The following is a description of a gene set: Mouse Gene Set: GOCC_ENDOSOME studied in species Mus musculus A vacuole to which materials ingested by endocytosis are delivered., and this is the list of marker genes: Ap3m2 (adaptor-related protein complex 3, mu 2 subunit), Ptp4a3, Epha4, Cd2ap, Arrdc5, Il12b, Kcnq1, Itm2b, Mmd (NCBI Gene Id 69866), Rab7, Havcr2, Pla2g3, Commd1, Inhca, Gatd1, Rhoa, Tbc1d5, Mgrn1, Rhov, Atp6v0d2, D130043K22Rik, Atp6v1e1, Magi2, Rab27a, Parm1, H2-DMb1, Ackr2 (atypical chemokine receptor 2), Snx32, Snx11, Tpp1, Yipf1, Rab22a, Igf2r, Myo5b (NCBI Gene Id 383414), Ap1g2, Tpcn1, Rab23 (NCBI Gene Id 98704), Ehd1, Dbnl, Psap, Siglec1, Rab4a, Rffl, Rap2a, Tmem106b, Sla2, Rab5a, Ociad2, Tnk2, Tpcn2, Nipa1, Ap5b1, Washc1, Pigr, Snx21, Tmem30a, Leprotl1, Litaf, Slc2a2, Pacsin3, Cltc, Nsg1, Rabep2, Snx16, Dennd6b, Ptp4a1, Plekhj1, Kif16b, Derl1, Ifnar1, Cd164 (NCBI Gene Id 53599), Tnik, Ykt6, Chmp7, Pla2g4e, Smpd1, Scoc, Ntrk1, Pip5k1c, Ccr3, Snx18, Fzd7, H2-M10.4, Atp6v0d1, Sun2, Rftn1, H2-DMb2, Furin, Abhd6, Kcnk1, Slc9a3, Lztr1, Cmtm6, Ifitm2, Abcc5, Tubgcp4, Slc9a8, Dnm2, Cdip1, Cc2d1b, Dnm1l, Cst7, Rabep1, Rabgap1l, Arhgap44, Ap1s1, Slc9a5, Psen1, Mr1, Rab35, Rab11fip5, Atp6ap2, Lhcgr, Scamp4, Rnf167, Anxa8, Snx14, H2-Eb1, Vps39, Ap1b1, Grip1, Steap4, Plekhb2, L1cam, Entrep1, Ehbp1l1, Apoe, Slc2a4, Ap3b2, Vps13b, Rnf148, Sh3gl2, Pacsin2, Vps26a, Tnfaip1, Vps51, Arl8b, Sftpa1, Gosr2, Tmem150b, Arc, H2-M11, Tpt1, Ap1m1, Sdf4, Tbc1d14, Exoc8, Uevld, Mreg, Chmp3, Washc5, Tmem184a, Smo (smoothened, frizzled class receptor), Ngf, Ackr3, Fyn, Gnas, Rab11fip2, F2r, Ephb1, Trappc14, Coro1a, Rap2b, Trim27, C9orf72, Rab13, Inpp5b, Zdhhc11, Syt5, Syt11, Gja1, Hap1, Fzd5, Chmp5, Lamtor2, Hyal3, Cyba, Rab7b, Rab5c, Rapgef1, Slc11a2, H2-M10.6, Ap3s2, Traf3, Nedd4l, Nipa2, Acap1, Ctsd, Ldlrad4, Yipf2, Epha8, Bsg, Ehd3, Dtnbp1, Ptpn1, Tmem108, Tom1l1, Pank1, Plin3, Ncf4, Rasgef1b, Neurl1b, Akt2, Ret, Prkar1b, Slc36a2, Marchf3, Diaph3, Pheta1, Ccdc154, Rufy1, Ehbp1, Kir3dl1, Chmp4b, Phb1, Coro1c, Mrc1, Ubr4, Laptm4b (NCBI Gene Id 68111), Ap3m1, Pdcd6, Laptm4a, Inpp4a (inositol polyphosphate-4-phosphatase, type I), H2-M10.1, Gpnmb, Zdhhc1, Lamtor5, Oprm1, Ocrl, Fcgr2b, Snx25, Map1lc3a, Atg9a, Vamp3, Mon1b, Tmem163, Cxcr4, Arhgap1, Vps53, D6Wsu163e, Stx12, Tsg101, Tjap1, Psen2, Abca7, Atp7b, Slc48a1, Osbpl11, Vps4a, Myh9, Napepld (NCBI Gene Id 242864), Rab14, Tyrp1, Rps6kc1, Osbpl9, Ctse, Dio3, Ifitm3, Oca2, Fchsd1 (NCBI Gene Id 319262), Kcmf1, Slc30a3, Tm9sf4 (transmembrane 9 superfamily member 4), Wdr81, Tlr9, Rilp, Gzmb (NCBI Gene Id 14939), Slc5a1, Rac1, Rab20, Tgoln1, Hgs, Chid1, Ap1s3, Washc2, Cryzl1, Tmem175, Pi4k2a, Itgb1, Mvb12b, Uvrag (UV radiation resistance associated gene), Dll3 (delta like canonical Notch ligand 3), Snx20, Zfyve21, Plekhf1, Lgmn (NCBI Gene Id 19141), Abca5, Lipc, Myo1d, Cblif (NCBI Gene Id 14603), Atp13a5, Lamp1, Rnf133, Tmbim1, Pikfyve, Gapdh, Erbb2, Ehd2, Astn1, Bdkrb2, H2-T22, Ctss, Rab4b, Bloc1s1 (NCBI Gene Id 14533), Epha3 (Eph receptor A3), Pick1, Atp1a1 (NCBI Gene Id 229653), Slc26a7, Bltp3b, Numb, Steap3, Cts8, Eipr1, Amotl2, Cln6 (NCBI Gene Id 76524), Lmtk2, Trappc6b, Ubap1l, Agtr1a, Arrdc3, Sec31a, Trim3, Flot1, Chmp2b, Rab9, Grb2, Vamp5, Stambpl1, Arf1, Vps41, Nucb1, Slc46a2, Pip4p1, Trappc4, Dysf, Ccdc120, Mitd1, Apoa5, Epn2, Ankrd13d, Rnf149, Tbck, Ptpn23, Nox1, Fcgrt, Tlr8, Myo1b, Hsd17b6, Cytip, Ackr4, Rab31 (RAB31, member RAS oncogene family), Washc4, Amn, Ide, Negr1, Kif21b, Gpc1, Sppl2b, Grin2b, H2-Q1, Ccdc22, H2-Q6, H2-M5, Pi4k2b, Atp9b, Exoc4, Rab9b, Ap1s2, Sorl1, Tbc1d17, Vps33b, Rap2c, Ctns, Mfsd12, Sorcs2, Slc31a1, Zfyve28, Micall2, Tgfb2, Atp6v0a4, Snx8, Mapk3, Ap5s1, Rab8b, Tmub1, Rnf128, Vps25, Hps5, Abhd17b, Il12a, Zdhhc2, Vcam1, Crhbp, Rab37, Fgd5, Mib2, Mapkap1 (mitogen-activated protein kinase associated protein 1), Tmem25, Rab24, Ube2d3, Ankrd13a, Atp11a, Hps6, Prkcz, Rab3c, Wdr48, F8a, Rab27b, Atp10b, Avpr1a, Eea1, H2-Q10, Bst2, Vps29, Osbpl1a, Acap2 (ArfGAP with coiled-coil, ankyrin repeat and PH domains 2), Hspa8, Cdk2, H2-Q7, Vps35l, Trappc9, Chmp6, Vps50, Mvb12a, Ifitm7, Pmel, Tmem45b (NCBI Gene Id 260382), Lamp2, Snx1, Tspan15, Ptprf, Syndig1, Rab38, Snx10, Slc11a1, Dgkh, Slc26a9, Dop1a, Ticam2, Arpc2 (NCBI Gene Id 76709), Dync1li2, Atp9a, Gper1, Caly, Dcstamp, Samd9l, Pld1, Gpr61, Map2k1, Vac14, Snx31, Sppl2a, Cd300ld3, Stard3, Tmem127, Clip1, Slc9a7, Prkci, Clcn3, Clip3, Ptprn, Clcn6, Becn1, Bace1, Prkcd, Nf2, Mon1a, Leprot, Eqtn, Sh3gl3, Kcnj11, Trf, Zmpste24, Ap3b1, Mcoln1, Scamp1, Snx2, Arhgap26, Wipi1, Abcg4, Atp6v0a2, Pld4 (NCBI Gene Id 217885), Enthd1, Vamp4, S1pr1, Rab15, Rassf9, Dagla, Ap3d1, Gimap5, Birc6, Vps35, Ezr, Rcsd1, Snx4, Pla2g4b, Gpr135, Lrp2, Insr (insulin receptor), Arrb2, Ncdn, Myo5a, Uts2r, Appl2, Cacng7, Tpd52l1, Slc9a9, Stam, Dennd2b (NCBI Gene Id 76954), Fgd2, B2m, Anp32e, Thsd1, Tm9sf2, Arrdc4, Cptp, Ntrk2, Scamp3, Vamp8, Adcyap1r1, Epn1 (epsin 1), Hmgb1, Trappc2l, Nmnat2, Gga3, Meltf, Tuba1a, Snx30, Rd3, Tlr7, Rab5b, Trappc13, Kidins220, Fig4, Rep15, Ccr5, Appl1, Sort1 (NCBI Gene Id 99747), Bet1l, Sftpc, Rab33a, Akap5, Siah2, Bloc1s2, Rab11fip4, Mcoln2, Wdfy1, Scamp5, Zfyve16, Serpinb1a, Znrf2, Tlr3, Slc39a14, Atp13a3 (NCBI Gene Id 385637), Tmem9b, H2-Ea, Rapgef2, Or51e2, Osbpl6, Mtmr4, Vps37b, Golim4, Abcb6, Folr1, Apbb2, Tcirg1 (T cell, immune regulator 1, ATPase, H+ transporting, lysosomal V0 protein A3), Ecpas, Slc15a3, Tnf, H2-Eb2, Slc6a5, Abca3, Ap3s1, Ankrd27 (NCBI Gene Id 352948), Tbc1d12, Avl9, Tasl, Rab3a, Slc2a13, Mtm1, Rap1gap, Agap2, Aqp2, Anxa1, Abca1, Gripap1, H2-K1, Ccz1, Atg9b, Arap1, Dnajc13, Spns2, Anxa2, Nisch, Rab11b, Zfyve26, Ndfip1, Grn, Arfgef2, H2-M2, Usp8, H2-M10.2, Rab34, Rmc1, Entr1, Vps37d, Ccdc115, Stam2, Cubn, Stx6, Ms4a2, Sftpd, Arpc5, Zfyve27, Rab33b, Stmn2, Abca2, Mical1, Plekha3, Dync1li1, Pheta2, Treml4, Plekhf2, Lpar1, Vps4b, Ptpn2, Ociad1, Dennd10, Pmepa1, Vps13c, Ube2a, Snx3, Cdkn1b (NCBI Gene Id 12576), Pik3c3, Mbl1, Als2, Lamp3, Abcg1, Rab29, Snx7, Mamdc4, Mctp1, Ldlrap1, Rubcn, Snx6 (NCBI Gene Id 97830), Rnf11, Elapor1, Nrp1, Slc46a1, Mmp14, Cftr, Marchf2, Vps37c, Ffar4, Chmp1a, Trappc10, Rab1a, Slc30a2, Lrp6, Siah1a, Washc3, Prss16 (NCBI Gene Id 54373), Atg16l1, Rab40b, Ap1ar, Map2k2, Vps37a, Dtx3l, Ifitm1, Tmem63b, Unc13d, Clec16a, Tgfbr1, Atp8a2, Kifc1, Tfrc (transferrin receptor), Aoc3, Sla, Lamp5, Vipas39, Ap4m1, Calcrl, Atp7a, Gria1, Cc2d1a, Trak1, Atp1a2, Arl8a, Chmp1b2, Ubxn6, Lrat, Tubg1, Mfsd8, Kdr, Creg1, Aph1a, Galntl5, Dync1i1, Golph3, Cntnap2, Rbsn, Trak2, Tmem230, Neurl3, Ace, Pdcd6ip, Lamtor3, Fyco1, Tmem192, Litafd, Cd274, Tollip, Rabgef1, Mtmr2, Tmem63a, Fgfr4, Clstn1, Steap1, Pml, Rabepk, Mcoln3, Tgfbrap1, H2-Aa, Vopp1, Cd300lg, Plpp2, Gga1, H2-Q2, Kcnh1 (NCBI Gene Id 16510), Tbc1d16, H2-D1, Rnf32, Micall1, Gapvd1, Clvs1, Plekhm2, Snx17 (NCBI Gene Id 76067), Lrrk2, Gga2, Trio, Relch (NCBI Gene Id 75582), Flt1, Gpr161, Sh3glb1, Tmem9, Trappc2, Grb14, Atp11b, Sbf2, Hps3, Tom1, Bok, Syt3, Mlc1, Sytl4, Trappc1, Vps36, Uba1, Ndrg1, Nme1, Kif13a, Ticam1, Ldlr, Arrb1, Wdfy4, Slc31a2, Slc9b2, Rhob, Git1, Snx13, Wdfy2, Vps26c, Praf2, Wls, Snf8, Abcb11, Src, Ankrd13b, Slc38a9, Lrpap1, Ece1, Cd22, Cd74, Slc30a10, Mpeg1, Slc66a2, Dner, Cln3, Tlr13, Cckar, Baiap3, Atp11c, Rab10, Rnd2, Bin1, Atp6ap1, Pld3, Npc1, Rab40c, Clvs2, Nsg2, Cyb561a3, Slc30a4, Fchsd2, Zfyve9 (NCBI Gene Id 381539), Slc34a1, Nbr1, Aqp4, Slc35d3, Adcy5, Gigyf2, Rab26, Rin3, H2-M3, Cd79a, Ap1g1, Cd68, Slc39a4, H2-DMa, Arsa, Cts7, H2-Ab1, Clcn5, Lipg, Sftpb, Crhr1, Stard3nl, Gpr15, H2-Oa, Cd1d2, M6pr, Gpr107, Wdr44 (NCBI Gene Id 72404), Ncstn, Gp2, Atp6v0b, Gfra1, Usp10, Wdr72, Rcc2, Hfe, Ctsl, Plekhm1, Prkar1a, Tab2, Mme, Ppp1r21, Tmem165 (NCBI Gene Id 21982), Magel2, Gcgr, Vps11, Rnft1, Pdlim4, Mbl2, Ap5z1, Rab17, Ccdc93, Adrb1, Scyl2, Rnf13, Mmgt2, Snx12, Rap1a, Cd63, Bace2, Abhd17c, Inpp5f, Rusc1, Adrb2, Siah1b, Optn, Cd1d1, Slc6a9, Snx5, Vti1b, Ehd4, Acp3 (NCBI Gene Id 77915), Adcy6, Mon2, Astn2, Eps15, Pla2g5, Ackr1, Unc93b1, Gnpnat1, H2-Ob, Sqstm1, Prdx3, Vps52, Stambp, Pacsin1, Marchf1 (NCBI Gene Id 72925), Spast, Zp2, Sgk3, Slc17a8, Prf1, Kir3dl2, Ptp4a2, Atp13a4, Wasf2, Angptl3, Abhd17a, F2rl1, Spaar, Rab11fip3, Lamtor1, Atf6b, Rab11a, P2ry2, Ltf, Vps33a, Pak3, Stx4a, Stx8, Sh3gl1 (SH3-domain GRB2-like 1), Cav1, Arhgap32, Rab21, Rab25, Tom1l2, Arhgap10, Chmp1b, Mkln1, Marchf8, Ankfy1, Itch, Fshr, Anxa6, Vps45, Slc15a4, Hspd1, Rnf112, Tlr4, Rab3b, Shc1, Mapk1, Notch1, Tmem59, Sting1, Vps16, Clint1, Rhod, Vps28, Itsn1, Rab3d, Wipf3, Vps26b, Pip4p2, Rab12, Ran, Atp13a2, Vta1, Slc29a3, Picalm, Vps18, Lamtor4, Exph5, Ubap1, Fcmr, Fkbp15, Vps13a, Clcn4, Avpr2, Stoml1, Llgl1, Egfr, Gpr62, Wdr91, Dop1b, Grap2, Snap25, Cst3, Htt, Bloc1s6, Tbc1d2b, Rab11fip1, Steap2, Trappc5, Slc17a6, Pik3r4, Sptbn2, Carmil1, Ttpa (tocopherol (alpha) transfer protein), Derl2, Arhgap27, Pkn1, Nae1, Flot2 (flotillin 2), Ddit3, Or2a7, Cpne6, Trappc3, Mmgt1, Chmp2a, App, Slc1a1, 2610528J11Rik (RIKEN cDNA 2610528J11 gene), Stx7, Lrp1, Neu3, Ank2, Slc5a7 (NCBI Gene Id 63993), Snx27, Epn3, Slc6a4, Znrf1, Rab8a, Ap5m1, Carmil2, Dennd6a, Arf6, Htr4, Scamp2, St8sia2, Irgm1, Sphk1, Rab32, Pcsk9, Cdh1, Slc9a6 (NCBI Gene Id 236794), Dgkq, Bltp3a, Chmp4c, Vps8, Vti1a